Given this list of marker genes NTRK2, TMEM108, FAM193A, BTAF1, HMGCR (NCBI Gene Id 3156), SMAP1, TCEAL7, TMEM135, TBC1D2B, SYNE2, SEPTIN7, C15orf40, TCEAL8, MAPK8, SORT1, TCEANC2, SYT1, CBX5, KDR, ZFAND3, PSAP, PSME3IP1, WIPF3, ENTPD1, ZNF74, PDE1B, ZNF629, ELP5, LRCH1, PANK3, AAK1, FAT1 (NCBI Gene Id 2195), EFHD1, RALB, AFG2B, WDR1, DNASE2, HDHD2, PHLDB1, YARS2, JPT1, CNTNAP4, CAMK2G, APPL2, MACIR, DCAF11, LRATD1, SPRR2E, ARHGAP21, GALNTL6, SEC23A, ZBTB4, MAPK6, BAIAP2L1, GRIK2, NR4A3, HIPK1, RSBN1L, CUL3, SLC16A10, PRKG1, REPS2, GRAMD1B, SLC19A2, FAM199X, ATP6V1C2 (NCBI Gene Id 245973), RHOBTB3, LPP, CDC27, CRACD, DDX3X, ATP10B (ATPase phospholipid transporting 10B (putative)), SCAF11 (NCBI Gene Id 9169), AREL1, MTHFSD, CACHD1 (NCBI Gene Id 57685), ZNF544, here is a description of the gene set: Genes predicted to be targets of miRBase v22 microRNA hsa-miR-664a-5p in miRDB v6.0 with MirTarget v4 prediction scores > 80 (high confidence targets). Human Gene Set: MIR664A_5P studied in species Homo sapiens from publication Chen Y, Wang X (PMID 31504780)